The following is a description of a gene set: A process in which an iron ion is transported from one side of a membrane to the other by means of some agent such as a transporter or pore. Mouse Gene Set: GOBP_IRON_ION_TRANSMEMBRANE_TRANSPORT studied in species Mus musculus, and this is the list of marker genes: Abcb7, Slc11a1, Scara5, Slc11a2, Hamp, Nos1, Ifng, Fxn, Steap4, Hif1a, Slc39a8, Mcoln1, Atp7a, Abcc5, Abcb6, Slc40a1, Slc25a28, Iscu, Lcn2, Steap3, Mcoln2, Heph, Slc48a1, Steap2, Tfrc, Steap1, Mmgt1, Slc25a37 (solute carrier family 25, member 37), Hamp2, Slc39a14